Given this list of marker genes Lrrc42 (leucine rich repeat containing 42), Plxna4, Klhl31, Fbxl17, Zmym2, Eci3, Aldh3b3, Thbd, Kcnk10, Chmp4b, Jhy, Septin10, Sipa1l2, Fchsd2, Myh15, Dbt, Psd3, Kctd21, Hoxd1, Usp9x, Card6, Ugt2b35, Tceal1, Eloc, Slc6a8, Phactr2, Tgoln1, Bach1 (BTB and CNC homology 1, basic leucine zipper transcription factor 1), Dpysl5, Tram1, Angpt2, Ehbp1, Gucd1, Gm5591, Fbxl3, Sybu, Yes1, Zfp2 (NCBI Gene Id 353051), Avpr1a, Cript, Serpinb6b, Prdm13, Grhl1, 3425401B19Rik, Ercc4, Trmt10a, Zc3h6, Plekhb2, Dhx36, Tex2, Itm2c, Frs2, Glrb, here is a description of the gene set: Genes predicted to be targets of miRBase v22 microRNA mmu_miR_31_3p in miRDB v6.0 with MirTarget v4 prediction scores > 80 (high confidence targets). studied in species Mus musculus from publication Chen Y, Wang X (PMID 31504780) Mouse Gene Set: MIR_31_3P